The following is a description of a gene set: studied in species Homo sapiens An anomaly of cerebral veins. Abnormal cerebral vein morphology Human Gene Set: HP_ABNORMAL_CEREBRAL_VEIN_MORPHOLOGY, and this is the list of marker genes: RASA1, EDN1, PLCB4, ZSWIM6, CBS, EPHB4, MSX2, GNAI3 (NCBI Gene Id 2773), ALX4 (NCBI Gene Id 64068)